Given this list of marker genes Prdx1, here is a description of the gene set: This event has been computationally inferred from an event that has been demonstrated in another species.<p>The inference is based on the homology mapping from PANTHER. Briefly, reactions for which all involved PhysicalEntities (in input, output and catalyst) have a mapped orthologue/paralogue (for complexes at least 75% of components must have a mapping) are inferred to the other species. electronically inferred by orthology from the curated human pathway Reactome Pathway: NFE2L2 regulating anti-oxidant/detoxification enzymes studied in species Mus musculus part of: Nuclear events mediated by NFE2L2